Given this list of marker genes Shprh, Megf9, Atosa, Vapb, Esr1, Kif16b, Pi15, Or7d10 (NCBI Gene Id 258336), Ppp3r1, Rfx6, Dmrt3, Rbm11, Gab1, Smarca5, Trabd2b, Bbc3, Tet1, Tmem236, Erbb4, Far1, Ap3b2, Clvs2, Mia3, Bend4, Dcaf12, Cnr1, Fos (FBJ osteosarcoma oncogene), Atp1b1, Slfn8 (schlafen 8), Thoc1, Gnb3, Rnps1, Casz1, Bmf, Ptbp3, Ptprz1, Eif3j1, Sybu, Fgf14, Cdkn1b, Btg2, Mark1, Ddit4, Plekha2, Sbk1, Vmac, Wdr47, Brwd3, Rev3l, Tnrc6c, Kit, Creg2, Mylip, Adipor1, Pramel22, Fermt2, Paip1, Tmem165, Rab1a, Cbfb, Irx5, Hipk1, Hmbox1, Mllt6, Agtr1a, Dcun1d1, Bcl2l11, Gabra1, Gas2, Gpr155, Nkiras1, Gabra2, Gnai2, Cldnd1, Mapk6, Galnt18, Foxn2, Arhgef7, Vash1, Zfp385a, Trim36, Dpp8, Fndc3a, Gucy1a2, Sun2, Syn3, Brwd1, Rcbtb2, Fmr1, Tshr, Rfx7, Midn, Zbtb4, Etv3, Ilf2, Eif3j2 (eukaryotic translation initiation factor 3, subunit J2), Scai, Mier3, Plekhb2, Upf3b, Tle3, Cdh2, 2510009E07Rik, Braf, Chsy1, Tmcc1, St6galnac3, Sparcl1, Nfyb, Plcl2, Adar, Clec1a, Prrg3, Atxn1, Cdk19, 4930544G11Rik (NCBI Gene Id 67653), Exo1, Ralgapa1, Fat2, Zfp869, Arf4, Hectd2, Trp53bp2, Tcf12, Pramel27, Dennd1b, Slc15a5, Hapstr1, Sema6d, Pik3r1, Fry, here is a description of the gene set: studied in species Mus musculus Mouse Gene Set: MIR_221_3P from publication Chen Y, Wang X (PMID 31504780) Genes predicted to be targets of miRBase v22 microRNA mmu_miR_221_3p in miRDB v6.0 with MirTarget v4 prediction scores > 80 (high confidence targets).